Given this list of marker genes ILK, ITGB1BP1, PREX1, RREB1, HAS2, LIMS1, TESK1, RAC1, RCC2, MYOC, DOCK1, CALR, S100A10, CSPG5, CARMIL1, NRP1, UNC13D, CORO1C, HTN1, ARPC2, RAC3, PDPN, AP1AR, C1QBP, CDC42, LIMS2, EFNA5, FLNA, CRKL, CASS4, MYADM, POSTN, DAB2, FGA, MELTF, GBP1, P4HB, ABL1, TRIOBP (TRIO and F-actin binding protein), CIB1, FGB, PTK2, TACSTD2, OLFM4, APOA1, DOCK5, NEDD9 (NCBI Gene Id 4739), SPRY4, ARHGEF7, PKP2, DMTN, FGG, BRAF, ITGB3, ACTN4, WASHC2C, FBLN1, CRK, FERMT2, MDK, KANK1 (KN motif and ankyrin repeat domains 1), here is a description of the gene set: studied in species Homo sapiens Human Gene Set: GOBP_REGULATION_OF_SUBSTRATE_ADHESION_DEPENDENT_CELL_SPREADING Any process that modulates the frequency, rate or extent of substrate adhesion-dependent cell spreading.